The following is a description of a gene set: Mouse Gene Set: WP_SREBF_AND_MIR33_IN_CHOLESTEROL_AND_LIPID_HOMEOSTASIS SREBF and miR33 in cholesterol and lipid homeostasis studied in species Mus musculus, and this is the list of marker genes: Hmgcr, Mir33, Ppara, Med15, Srebf1, Sirt6, Nr1h3, Ldlr, Ppargc1a, Sirt1, Srebf2, Mtor